Given this list of marker genes CA3, COL23A1, ITGB1BP2, MITF (NCBI Gene Id 7487), MYO1E, GPR20, LDB1, CIPC, FLNA, DUSP10, HOXC4, CITED2, EGR3, RIMS1, TFAP2D, RARB, GGN, TLE3, CALD1, ZNF485, STAT5B, CRH, NFATC4, FOXP2, PDLIM5, TAGLN, ACTR3, STX10, AAMDC, MYL11, RSF1 (remodeling and spacing factor 1), MYH11, YBX3, SLC4A3 (NCBI Gene Id 7858), ABCA1, CXCL6, MYADM, ADAMTSL1, MAP2K6, OTX1, HTN1, EGR2, CORO1C (NCBI Gene Id 23603), MAPKAPK2, RSU1, PLCB3, PRM1, SHF, FLNC, FGF7, PRUNE2, GADD45G, ACTB, ASB2, TRIM46, MRPS21, DLL1, HOXC5, ANXA6, ITGB6, HAPSTR1, TMEM47, PLPP3, LRRFIP1, RUNDC1 (NCBI Gene Id 146923), KLF6, FOSB, NRAS, PELI2, FGFRL1, GRK6, PRR14L, EGR1, FAM131B, SUSD1, DGKG, UBE2H, SERTAD4, EMILIN2, GPBP1, LCP1, MAP3K20, PPP1R12A, PRMT3, EFHD1, CACNA1B, EVA1C, MLIP, CSRP1, SVIL, TAFAZZIN, KDM3A, FOS (Fos proto-oncogene, AP-1 transcription factor subunit), PCDH7, TPM2, IER2, DSTN, GPR162, VCL, PTCH1, MRGPRF, PADI2, TRDN, RBBP7, DUSP5, CXCL5, KCNH2, ATF4, ACTC1, PFN1, NR2F2, HOXD10, G3BP2, HOXB5, SLC16A6, RASSF2, ASPA, ZNF513, MED13, NKX2-2, CNN1, NPPA, MUS81, FGF8 (fibroblast growth factor 8), SLC25A4, CTNND1, ACTA1, CDKN1B, TNMD, ARPC4, KRTCAP2, NPR3 (NCBI Gene Id 79614), ITGB8, RAI2 (retinoic acid induced 2), IL17B, PHF12, BNC2, TANK, SCOC, FAM53C, ACTN1, DIXDC1, NR2F1, TGFB1I1 (transforming growth factor beta 1 induced transcript 1), CNN2, MYADML, LIX1L, FOXP1, ERBIN, H2AX, NOB1, FOXE3, FGF17, DVL3 (dishevelled segment polarity protein 3), CAVIN2, MYLK, H3-3A, TRIM3, JUNB, SLC2A4, CD248, PODN, MBNL1 (NCBI Gene Id 9850), TADA3, PRKAB2, SGK1, MID1, ELAVL4, COX14, TPM3, FOXO4, CDC25B, VASP, AARSD1, BLOC1S1, PDLIM7, PICALM, IGF2-AS, TMEM126A, ZNF644, XK, LRRTM4, CASQ1 (calsequestrin 1), CFL2, NPAS2, PLN, ACTG2, SRF, COL1A1, MAPK14, CKM, RHOJ, CHST8, EML4, AKIRIN2, CALN1, KCNA1, TIMP3, PPARG, KCNK3, ARF6, SRD5A2, ATF3, RERE, THBS1 (thrombospondin 1), NPAS4, ASXL2, MYL9, CHD2, ABR, TAF5L, STARD13, MAP1A, HOXB4, MYL7, ADGRG4, PPP2R3A, NRXN3, MYL6, ZBTB18, CFL1, SUN2, EEF1B2, LPP, WNT3, here is a description of the gene set: Genes having at least one occurrence of the motif CCAWATAWGGMNMNG in the regions spanning 4 kb centered on their transcription starting sites. This matches the SRF transcription factor binding site V$SRF_Q5_01 (v7.4 TRANSFAC). studied in species Homo sapiens Human Gene Set: SRF_Q5_01